The following is a description of a gene set: Removal of the transcription factor SAP1a member of the Ternary Complex Factor (TCF) group of transcription factors which in conjunction with Serum Response Factor (SRF) has been shown to have a profound effect on positive selection in the thymus. When another TCF Elk1 is knocked out in mice there is no effect on positive selection unless it is on a Sap1a KO background where the phenotype is very severe. We have stimulated isolated double positive T cells (DPs) with anti-CD3 to mimic positive selection and compared basal and stimulated transcription across the four genotypes to discover the downstream targets of Sap1a involved in positive selection. from publication Costello P, Nicolas R, Willoughby J, Wasylyk B, Nordheim A, Treisman R (PMID 20554967) Genes up-regulated in untreated double positive thymocytes: wildtype versus ELK4 knockout. Human Gene Set: GSE21546_WT_VS_SAP1A_KO_DP_THYMOCYTES_UP species: Homo sapiens, and this is the list of marker genes: CYLD, UBASH3A, PARP9, BIRC2, SOX9, ISG15, IL13RA2 (interleukin 13 receptor subunit alpha 2), PARP14, IFI27, RBM43, DDX60L, SAMD9, RABGEF1P1, PSME2, TAP2, MT1G, RNF13, CARINH, IFIH1, ZNF879, IFI16, STAT1, CASP7, IFI44, HLA-G, CSRNP1, DDX60, THEMIS2, MYD88, TAPBPL, BST2, WDR25, GBP3, GUCD1, ADGRG6, SAT1, BDH2, IFI35, NECTIN2, LINC01101, SPATS2L, BTN3A2, CILK1, IFI44L, GMPR, B2M (beta-2-microglobulin), BAZ1A, PRPF3, CMPK2, USP18, PATL1, CHRAC1, MX2, HLA-E, TRIM56, SIDT2, TEX36-AS1, HLA-C, IFITM1, TREX1, HERC6, NRG2, BCL2L13, PSMG2, TMEM140, MT1HL1, LGALS3BP (NCBI Gene Id 3959), OPTN (NCBI Gene Id 337928), RSPO1, APOL2, IRF2, TAP1, TRIM26, PARP12, CSNK1G1, OGFR, ARSD, MT1X, TRIM14, MOV10, LNPEP, ANKRD55, OAS1, IRF7, ANKIB1, HEG1, SYNJ2BP, MX1, LAP3, XAF1, TRANK1, PRKD2, ADAR, IFIT3, BATF2, HLA-B, RSAD2, ADRA2A, SERPINE1, FAM111A, SAMHD1, NMI, DNAJA1, GNB4, GSG1 (germ cell associated 1), TENT5A, NLRC5, RNF213, CMTR1, TRIM25, UBE2D2, TRIM5, CDK5RAP1, BLTP3A, IFIT1, CX3CL1, DTX3L, HELZ2, IFITM2, RIGI, TRERF1, LIMA1, TDRD7, MSX1, GBP1, RBCK1, ETV7, OAS3, TRIM22, FMR1NB, ZC3HAV1, AKAP6, IFIT5, CALCOCO2, APOL1, SCAMP1-AS1, STAT2, CRYZ, PSMB9, SLC25A28, PHF11, VEZF1, EHD4, NUB1 (negative regulator of ubiquitin like proteins 1), SNX25, PNPT1, BTN3A3, ANKFY1, TRIM38, PFKFB3, MT1H, DHX58, H1-9P, SERTAD1, IFIT2, PSMB8, CD274, B3GALT5-AS1, SP110, SAMD9L, GNL2, PLSCR1, MT2A, DNPEP, CXCL10, OASL, UBE2L6, GABRA2, ZNFX1, EIF2S2, C4orf33, IFITM3, TRIM21, SHFL, ENSG00000229727, GPRC5A, PML, BTN3A1, ATP2B4, DNAJC13, LINC01091, KEL, CXCL11, PSME1, AGTRAP, ANGPT2, CASP1, TRIM69, HLA-F, VAMP5, TJP1, ABHD2, OAS2, PPM1K, EIF2AK2, IRF9, MIR770